Given this list of marker genes Slc1a5, Gfap, Slc25a18, Ucp2, Slc3a1, Lrrc8c, Lrrc8b, Ntsr1, Slc25a12, Lrrc8e, Slc25a22, Slc13a3, Slc25a13, Slc7a13, Lrrc8d, Prkcd (NCBI Gene Id 52581), Slc1a3, Slc1a1, Slc1a4, Slc1a6, Slc1a2, Lrrc8a, here is a description of the gene set: studied in species Mus musculus Mouse Gene Set: GOBP_ASPARTATE_TRANSMEMBRANE_TRANSPORT The process in which aspartate is transported across a lipid bilayer, from one side of a membrane to the other.